Given this list of marker genes LY86, PLEKHF2, EAF2, SNX3, ENTPD1, MS4A1, SLC7A7, ORAI3, AIM2, BLNK, MARCKS, MEF2A, CD79A, SYK, TCL1A, HLA-DQA1, HLA-DRA, SLC15A3, GFOD1, TMT1A (NCBI Gene Id 25840), CD40 (NCBI Gene Id 958), STAG3, TIMELESS, CR2, ADK, DUS2, IRF4, IGHA1, TLR7, MARCHF1, LTA4H, SCPEP1, SMAGP, TSPAN13, B4GALT1, RRAS2, MAP3K14, FCRL2, BCL11A, RHOBTB2, IGHD, PTPRK, CDK14, CD24, STX7, RHOQ, SP140, SYNGR2, HLA-DMB, FCHSD2, IRF8, CHST15, BCL7A, FAM3C (NCBI Gene Id 10447), H2BC12L, JUN, RAB30, LHFPL2 (LHFPL tetraspan subfamily member 2), IFNGR2, LARGE1, TCF4, PNOC, YBX3, EHD3, CD180, KIAA0040, TBC1D9, RFX5, LAMC1, VAV3, CD1D, GUSBP11 (GUSB pseudogene 11), SYNPO, CD1C, CLIC4, C11orf24, SHMT2, PLCG2, KMO, IGKV1D-13, IGLL3P (immunoglobulin lambda like polypeptide 3, pseudogene), GM2A, HLA-DQB1, CD19, SH2B2, SKAP2, CD79B, CLIP2, DDAH2, BEND5, DENND3, IGKC, CIITA, PKIG, TLE1, RNF141 (NCBI Gene Id 50862), PAX5, BTK, MIR600HG, NCF1C, TRAK1, HLA-DOB, IGLJ3, ABCB4, SEL1L3, IRF5, HLA-DMA, SETBP1, LMO2, GNG7, CD72, PRKCB, IGLV3-19, SPIB, TSPAN3, TUBB6, H2BC12, OPN3, JCHAIN, LYL1, IGHM, TBC1D5, SLC2A6, FCGR2C, GSE1, BANK1, STAP1, DYRK4, GGA2, OSBPL10, BASP1, SWAP70, NT5C, HDAC9, FAM30A, RUBCNL, CD200, ZMIZ2, FADS3, FCER2, ATP10D, RASGRP3, PTPN6, VPREB3, CACNA1A, CD22, ARHGAP17, ANXA4, COCH, TCTN1, RNASE6, PDLIM1, ARHGAP24 (Rho GTPase activating protein 24), IRAG2, IGKV4-1, HLA-DPA1, MEF2C, CXCR5, PLAC8, SYBU, BMS1P20, MZB1, TCF3, LYN, MICAL3, DHTKD1, P2RX5, SIPA1L1, BLK, WASF1, RABEP2, HLA-DRB6, DTX4, LAT2, SLC17A9, ADAM19, HLA-DRB1, SCARB1, TPD52, CYBB, CLCN6, IGLV1-44, RHBDF2, POU2AF1 (POU class 2 homeobox associating factor 1), PCDH9, ADAM28, CD83, ALOX5, QRSL1, HLA-DPB1, MTSS1, HHEX, DNMBP, FCGR2B, TFEB, here is a description of the gene set: Human Gene Set: GSE10325_CD4_TCELL_VS_BCELL_DN Gene expression profile studies have identified an interferon signature in whole blood or mononuclear cell samples from patients with systemic lupus erythematosus. This study was designed to determine whether specific lymphocyte and myeloid subsets freshly isolated from the blood of systemic lupus erythematosus patients demonstrated unique gene expression profiles compared to subsets isolated from healthy controls. from publication Hutcheson J, Scatizzi JC, Siddiqui AM, Haines GK 3rd, Wu T, Li QZ, Davis LS, Mohan C, Perlman H (PMID 18275831) Genes down-regulated in comparison of healthy CD4 T cells versus healthy CD19 B cells. studied in species Homo sapiens